Given this list of marker genes ALDH3A2, ABCD1, ACOX2, ACOX1, PECR, CROT, HAO2, ACBD4, ACOXL, HACL1, PHYH, NUDT19, ACOT4, CRAT (NCBI Gene Id 1384), ACOT8, SLC25A17, SLC27A2, ACOX3 (acyl-CoA oxidase 3, pristanoyl), SCP2, ACBD5, NUDT7, HSD17B4, DECR2, MLYCD, AMACR, ECI2, ACAA1, EHHADH, here is a description of the gene set: part of: Fatty acid metabolism In humans, the catabolism of phytanate, pristanate, and very long chain fatty acids as well as the first four steps of the biosynthesis of plasmalogens are catalyzed by peroxisomal enzymes. Defects in any of these enzymes or in the assembly of peroxisomes are associated with severe developmental disorders. Reactome Pathway: Peroxisomal lipid metabolism studied in species Homo sapiens